The following is a description of a gene set: studied in species Mus musculus Mouse Gene Set: MIR_7049_5P Genes predicted to be targets of miRBase v22 microRNA mmu_miR_7049_5p in miRDB v6.0 with MirTarget v4 prediction scores > 80 (high confidence targets). from publication Chen Y, Wang X (PMID 31504780), and this is the list of marker genes: Acrbp, Ripk1, Zdhhc9, Ddi2, Slc6a18, Mcur1, Socs5, Nrcam, Kcnd2, Aak1, Actmap, Prss53, Wnt5a, Sult1e1, Evi5, Cenpp, Mitf, Snx22, Samd4b, Fgd6, Zfyve27, Lipg, Rpa1, Col5a2, Xpc, Dsc3, Zc3h10, Bcl11a, Xndc1, Diras2, Kdm3a, Arhgap21, Mall, Mat2a, Npas3, Tnfaip2, Slc2a13, Zfp827, Col9a3, Zfp711, Slc7a8, Usp7, Marcks, Pgrmc2, Foxo1, Kcnj2, Rpl7l1, Cadm1, Eef1a1, Dlgap1, Trappc3, Fmo5, Ubl4b, Mideas, Elavl2, Larp4, Ifnk, Dclk1, Adgrg6, Ltbr, Elapor2, Vdac1, Hspd1, Pros1, Atp11b (NCBI Gene Id 76295), Skil, Sestd1, Atxn7l1, Rassf2, Gsdme, Slc1a3, Aff4, Dcun1d3, Epha7, Snrnp40, 2310002L09Rik, Parva, Rb1, Vil1, Ank3, Tkfc, Chic1, Sp1, Fyttd1, Atad2b, Agpat3, Atxn7l3b, Qpct, Srrm4, Cyb561d1, Cnr2, Arhgap17, Xkr6, Emilin3, Col19a1, Zfp24, Ahr, Nfasc, Tm9sf2, Spty2d1, Dkk2, Zfp276, Trim33, Eya3, Dusp6, Tceanc2, Pik3cb, Grem1, Eif4e3, Necap2, Kpna1, Tnfsf8 (tumor necrosis factor (ligand) superfamily, member 8), Serpinb5, Slc22a3, Exoc6b, Zfp764, Slc7a7, Snap29, Lancl1, Cand1, Piwil1, Zmat3, Klf9 (NCBI Gene Id 70273), Tnf, Ric8a, Slc66a1, Pknox2, Zfp872, Krtap4-25, Lypd6, Trim15, Acer3, Gria3, Idh3b, Rab2a, Arpp19, Cep55, Nr2e1, Eif4g3, Purb, Actr3b, Dpf3, Negr1, Tpgs2, Cpeb4, Kbtbd7, Btn2a2, Tnmd, Zhx3, Trim67, Ddc, Abca8a